The following is a description of a gene set: from publication Zheng H, Ying H, Yan H, Kimmelman AC, Hiller DJ, Chen AJ, Perry SR, Tonon G, Chu GC, Ding Z, Stommel JM, Dunn KL, Wiedemeyer R, You MJ, Brennan C, Wang YA, Ligon KL, Wong WH, Chin L, DePinho RA (PMID 18948956) The glioblastoma multiforme (GBM) plasticity signature: genes down-regulated in neural stem cells (NSC) with double knockout of TP53 and PTEN vs those with knockout of TP53 alone. Glioblastoma (GBM) is a highly lethal brain tumour presenting as one of two subtypes with distinct clinical histories and molecular profiles. The primary GBM subtype presents acutely as a high-grade disease that typically harbours mutations in EGFR, PTEN and INK4A/ARF (also known as CDKN2A), and the secondary GBM subtype evolves from the slow progression of a low-grade disease that classically possesses PDGF and TP53 events. Here we show that concomitant central nervous system (CNS)-specific deletion of p53 and Pten in the mouse CNS generates a penetrant acute-onset high-grade malignant glioma phenotype with notable clinical, pathological and molecular resemblance to primary GBM in humans. This genetic observation prompted TP53 and PTEN mutational analysis in human primary GBM, demonstrating unexpectedly frequent inactivating mutations of TP53 as well as the expected PTEN mutations. Integrated transcriptomic profiling, in silico promoter analysis and functional studies of murine neural stem cells (NSCs) established that dual, but not singular, inactivation of p53 and Pten promotes an undifferentiated state with high renewal potential and drives increased Myc protein levels and its associated signature. Functional studies validated increased Myc activity as a potent contributor to the impaired differentiation and enhanced renewal of NSCs doubly null for p53 and Pten (p53(-/-) Pten(-/-)) as well as tumour neurospheres (TNSs) derived from this model. Myc also serves to maintain robust tumorigenic potential of p53(-/-) Pten(-/-) TNSs. These murine modelling studies, together with confirmatory transcriptomic/promoter studies in human primary GBM, validate a pathogenetic role of a common tumour suppressor mutation profile in human primary GBM and establish Myc as an important target for cooperative actions of p53 and Pten in the regulation of normal and malignant stem/progenitor cell differentiation, self-renewal and tumorigenic potential. species: Mus musculus Human Gene Set: ZHENG_GLIOBLASTOMA_PLASTICITY_DN, and this is the list of marker genes: PRKCQ, LSAMP, RAMP1, MAPT, PVALB, CSPG4, LPAR1, RNASE1, DRAXIN, DDHD1, CADPS, EPHB1 (NCBI Gene Id 2047), BCL2L11, EMILIN1, PDLIM4 (PDZ and LIM domain 4), ZDHHC14, TSC22D1, COL6A2, RHOU, FOSB, THY1, CNGA2, TIMP3, SLC26A2, SERPINH1, TRIM5, CD109, EMP1, DZIP1, MXD4, PLAGL1, PSD2, ZFP36, PTGDS, FOSL2, SYN2, PCMTD2, ATP8A1, NISCH, CAV1, DCAF12L1, CRYAB, PCOLCE2, SORL1, ITGA7, NDRG2, COL9A3, TST, PADI2, MERTK, EFS, KCNA6, RDH5, ARVCF, PGM5 (phosphoglucomutase 5), COL4A1, ITGA5, CLU, PPFIBP2, CCN1 (cellular communication network factor 1)